The following is a description of a gene set: Human Gene Set: GOBP_HEMATOPOIETIC_STEM_CELL_PROLIFERATION The expansion of a hematopoietic stem cell population by cell division. A hematopoietic stem cell is a stem cell from which all cells of the lymphoid and myeloid lineages develop. species: Homo sapiens, and this is the list of marker genes: ERCC2, CEBPA, WNT1, ARIH2, KAT7, MECOM, GBA1 (NCBI Gene Id 82008), YJEFN3, WNT2B, NKAP, MIR221, KITLG, WNT5A, SNAI2, YTHDF2, SART3, ATXN1L, PIM1, EIF2AK2, SFRP2, TSC22D1, ANG, ACE, RUNX1, XRCC5, WNT10B, SHB, BABAM1, CTC1, HOXB4, CD34, PDCD2, N4BP2L2, MIR222, THPO, ETV6, BRCA2